Given this list of marker genes Defb25, Mcoln2, Ticam2, Mavs, Adcyap1, Trpv4, here is a description of the gene set: species: Mus musculus Mouse Gene Set: GOBP_POSITIVE_REGULATION_OF_CHEMOKINE_C_C_MOTIF_LIGAND_5_PRODUCTION Any process that activates or increases the frequency, rate, or extent of production of chemokine (C-C motif) ligand 5.